Given this list of marker genes PUS7, SNAPC2, RNF11, NIBAN2, ARAP3, IL2RG, IL1RN, TUBB, TRIM8, INPPL1, STIMATE, PAICS, PANX1, RNASEH2B, FGF11, RIOX2, AKIRIN1 (akirin 1), RHEBL1, ARMCX2, NOD2, PTGS1, ATP6V1G1, TSR3, EBNA1BP2, RHOC, ANKS1B, FANCC, NYAP2, EFR3B, SLC16A3, DNAJB5, VAC14-AS1, SLC25A19, ZBTB7B, UBE2G2, IL27RA, HMCES, NME1, CCT2, LRRC25, NAV1, CD180, ARL4A, UFSP2, TNFSF14, KIRREL3, PTGDS, C10orf71, STT3B, VDAC2, ABCE1, PLXND1, SLC52A1, IPO9, ATP5MK, RBM19, LINC01128, ABCC5, KIF1B, KCNN4, TNFRSF4, CFAP58, C1QTNF4, PNMT, C1QC, MMP8, C5orf34, ERI2 (ERI1 exoribonuclease family member 2), DCUN1D5, TLK2, ADGRE3, FTHL17, SNX24, RASA3, C21orf91-OT1, COL13A1, AP5S1, PTPN9, ZNF346, INTS6L, C5orf47, CBFA2T2, PCARE, TTLL1, ENSG00000235143, ENTPD1, EIF3I, BAZ1B, SLC39A13, MTX3, ZCCHC24, CLDN7, AHI1, LTBP2, GSG1, KHK, MRPL50, CDC42BPA, TTC9B, OCLN, DENND1B, CST8, TSPAN15, PSMD11, SCRIB, GSS, MCM3AP-AS1, ENG, S1PR2, BAG3, SREK1, SNRPB, MOB1B, ETHE1, APCDD1L, MGRN1, PFN1 (profilin 1), TOP6BL, UQCRFS1, GNPNAT1, STYX, DRAP1, TMEM134, C19orf18, ARHGAP9, LPAR5, TMEM74 (transmembrane protein 74), RPL7L1, UNC45A, CLRN1, CS, H4C13, PPP6R2, F13B, SH2B3, TCF3, CNPY4, NAA60, ZNF281, NDUFB2-AS1, SNRNP27, SLC30A7, PRMT3, PTGER4, WDR46, LINC03122, NUDT4, WDR54 (NCBI Gene Id 84058), TMEM62, PTPRO, ZEB1, TMEM86B (NCBI Gene Id 255043), SCHIP1, NRM, SCAMP3, KANK1, SLC27A4, PWWP2B, MRPL24, FTSJ1, SNAPC3, BRF1, ESD, GPR108, DYNC1LI1, CYBB, ZNRF1, SYNC, PSMD13, SLC39A12 (solute carrier family 39 member 12), UBXN8, MAP7, TSTD2, PLOD3, CDC7, MRPS5, PIGF, MRGBP, AQP2, METAP2, DCLRE1A, PHLDA2, GTPBP3, ZSWIM2, THAP8, PEBP4, PALS2, CLUAP1, FKBP14, STX4, EEF1B2, TFDP2, ORMDL1, TTC19, CMC2, here is a description of the gene set: Genes down-regulated in macrophages: untreated versus stimulated by IFNG for 24h. studied in species Homo sapiens IFN-gamma transcriptional responses in control and IFN-gamma primed primary human macrophages Human Gene Set: GSE1925_CTRL_VS_24H_IFNG_STIM_MACROPHAGE_DN from publication Hu X, Park-Min KH, Ho HH, Ivashkiv LB (PMID 16148108)